The following is a description of a gene set: Human Gene Set: HP_SHORT_THORAX Short thorax Reduced inferior to superior extent of the thorax. species: Homo sapiens, and this is the list of marker genes: DYNC2LI1, CUL7, DLL3, FGFR3, SLC10A7, NADSYN1, RNU12, BMPER, IHH, GLI1, TBX6 (T-box transcription factor 6), DYM, RIPPLY2, CEP120, PRKACB (NCBI Gene Id 5567), TTC21B, LTBP1, FREM2 (NCBI Gene Id 341640), ORC6, EVC, TRIP11, WDR35 (NCBI Gene Id 57539), SLC26A2, DYNC2H1, PRKACA, IFT80, COL2A1, PTH1R, RMRP, FLNA, EVC2, KIAA0753, NEU1, ACAN, SLC2A1, TRPV4, IFT172, CCDC8 (coiled-coil domain containing 8), IFT122, MESP2, IFT140, OBSL1, WDR19, IARS2, LFNG (LFNG O-fucosylpeptide 3-beta-N-acetylglucosaminyltransferase), IFT52 (NCBI Gene Id 51098), DYNC2I1 (NCBI Gene Id 55112), MBD5, DYNC2I2, HES7